Given this list of marker genes LDHB, LDHC, SUCLA2, FH, DLST, SUCLG2, SUCLG1, PDHX, MPC1, GPT, DHTKD1, PCK2, LDHA, here is a description of the gene set: species: Homo sapiens Human Gene Set: WP_KREBS_CYCLE_DISORDERS Krebs cycle disorders